Given this list of marker genes Strbp, Mzt1 (NCBI Gene Id 76789), Luc7l3, Cap1, Trip11, Serbp1, Wdr1, Adra2a, Ephb1, Dnm1, Gpatch11, Mical2, Kcna6, Snap25, Ccdc14, Lbh, Kctd4, Sh3pxd2a, Usp49, Tnfaip1, Psd, Fxyd6, Creb3l2, Dbt, Plscr1, Ap4e1, Sp1, Myadml2, Sfn, Rmi1, Cldn19, Foxr2, Zfp143, Dll3, Atg16l1, Rnf121, Patl1, Mpl, Rcc1, Mgat3, Rskr, Pitpnm3, Tbc1d10c, Lyve1, Tfdp2, Srsf7, Zfp24, Pigp, Gnao1, Slc35f1, Ranbp10 (RAN binding protein 10), Sarm1, Fut1, Grip2, Car12, Cd248, Avl9, Cys1 (NCBI Gene Id 72858), Itgb3, Apln, Ets1, 2010003K11Rik, Lix1l, Kcns2, Slc22a23, Chst7, Nrep, Tub, Sparc, Slc39a11, BC048644 (NCBI Gene Id 407789), Tbx18, Zbtb43, Sec22c, Zdhhc3, Nynrin, Ubqln4, Htr7, Tbc1d15, Trip10, Unc93a, Ret, Rhou, Adamts15, Kcng4 (potassium voltage-gated channel, subfamily G, member 4), Ybx2 (NCBI Gene Id 53422), Usf3, Cnih3, Mapk9, Ppfibp2, Zfp593, Trappc8, here is a description of the gene set: from publication Chen Y, Wang X (PMID 31504780) Mouse Gene Set: MIR_7050_3P Genes predicted to be targets of miRBase v22 microRNA mmu_miR_7050_3p in miRDB v6.0 with MirTarget v4 prediction scores > 80 (high confidence targets). studied in species Mus musculus